The following is a description of a gene set: Genes having at least one occurence of the motif TCTATGA in their 3' untranslated region. The motif represents putative target (that is, seed match) of human mature miRNAs hsa-miR-376a and hsa-miR-376b (v7.1 miRBase). Human Gene Set: TCTATGA_MIR376A_MIR376B studied in species Homo sapiens, and this is the list of marker genes: GRAMD2B, GRIN3A, GRIK2, GPR180, TRIM35, DLX5, ATP6V1G1, PEX12, VPS54, GRIK5, ZIC3, RBMS1, CUX2, ZMYND11, SEPTIN7, KCNIP2, ABRAXAS2, NIPBL, SGMS1 (sphingomyelin synthase 1), CAPN3, KHDRBS3, AGO2, SLITRK6, RAPGEFL1, FBXO11, SLC4A10, UBE2D2, VHLL, NFIB, CASP8, SCOC, PLAG1, PLEKHA5, ZBTB7A, ADNP (NCBI Gene Id 256440), DSCAML1, RAB1A, CRISPLD2, LARP4, RYBP, USP6, HNRNPA0, NDST1, PDIA6, NRP1, SLC6A1, CELF4 (NCBI Gene Id 56853), MBD5, PTMA, SIDT2, BRWD1, PDE8A, CSNK1G3, LAMC1, ENAH, EFCAB14, ROCK2, NUP58, RPL5, BPTF, ZNF663P, TRIM13, CEBPB, SETD7, PPP1R10, CAPZA1, BNC1 (basonuclin zinc finger protein 1), DCAF5, SYNE3, COPS7A, NFKBIZ, CNIH1, MACROD2 (NCBI Gene Id 284776), INSIG2, SMARCA2, BCL2L11, KPNA4, TM2D1, GPC6, FERMT2, HES5, ANK2, FAM131B, PTGES2, EIF4B